Given this list of marker genes MIR766, TMEM135, FADS3, ELOVL4, PNPLA8, PIBF1, SCD, CBR1, SIRT1, TBXAS1, ACOT8, SCD5, ACOX1, PTGIS, CTHRC1 (NCBI Gene Id 115908), HSD17B4, PRXL2B, FADS2, ELOVL3, FABP5, SCP2, PTGDS, AVP (arginine vasopressin), PLA2G4F, FADS2B, DECR2, ELOVL1, DEGS1, MIF, HPGDS, MIR132, ALOX15B, ELOVL6, ABCD2, PLA2G10, MIR204, ELOVL2, EHHADH, ELOVL7 (NCBI Gene Id 79993), FADS1, AKR1C3, ALOX12, PLA2G3, ACSL4, DAGLB, EDN2, ALOX15, EDN1, PTGES2, CD74, PTGS2, PTGS1, ABCD1 (ATP binding cassette subfamily D member 1), PLAA, PLA2G4A, AVPR1A, IL1B, ELOVL5, PTGES, PTGES3, here is a description of the gene set: species: Homo sapiens Human Gene Set: GOBP_UNSATURATED_FATTY_ACID_BIOSYNTHETIC_PROCESS The chemical reactions and pathways resulting in the formation of an unsaturated fatty acid, any fatty acid containing one or more double bonds between carbon atoms.